The following is a description of a gene set: Human Gene Set: GSE5589_WT_VS_IL10_KO_LPS_STIM_MACROPHAGE_180MIN_DN Genes down-regulated in bone marrow-derived macrophages at 180 min of stimulation by LPS: wildtype versus IL10 knockout. studied in species Homo sapiens IL-10 or IL-6 stimulation of control 129xC57BL/6 murine bone marrow derived macrophages in the presence of LPS. We used microarrays to detail the global programme of gene expression changes in response to IL-6 or IL-10 stimulation in the presence of lipopolysaccharide. BMDMs were isolated from control, IL-6-/-, and IL-10-/- mice on a 129XBL/6 mixed background mice and differentiated in the presence of CSF-1 for 6-7 days. Cells were scraped and plated in 6 well plates at 2x10e6/well. Cells were washed with complete DMEM and rested for 1-2 hr before stimulation with combinations of IL-10 (10 ng/ml), IL-6 (2 ng/ml) or LPS (100 ng/ml) for 45 min or 180 mins. Complete biological replicates were performed. from publication El Kasmi KC, Holst J, Coffre M, Mielke L, de Pauw A, Lhocine N, Smith AM, Rutschman R, Kaushal D, Shen Y, Suda T, Donnelly RP, Myers MG Jr, Alexander W, Vignali DA, Watowich SS, Ernst M, Hilton DJ, Murray PJ (PMID 17114459), and this is the list of marker genes: GRHL1, HPCAL1, IGHG3, CTSG, OPTN, ZNRF2, SLC34A1, NR3C1 (nuclear receptor subfamily 3 group C member 1), THBD, TNFRSF13B, GLT8D2, LIG1 (DNA ligase 1), THBS2, VIM, DDAH2 (DDAH family member 2, ADMA-independent), LRRC9, NXF2, FAM124B, MAN1B1, OOSP1, CASP14, KAZALD1, DMPK, OLFM2, FBLN5 (NCBI Gene Id 11268), RASL10B, NDUFA11, GSX2, TIE1, EPHX1, FOLR2, HEPACAM2, FCRLA, DHDH, SHC4, EPAS1, OLFM1, S100A11, CBS, STMN1, ADGRG4, VAV3, NINJ1, CCDC50, PARP3, TRPV1, SERPINB12, ARHGEF28, SSBP3, ITGA4, EPX, GPC1, HGFAC, SLIT2, IL27, HOXD3, MIR676, SCARB2, EEIG2, EMILIN1, CCR10, KIRREL1, KCTD19, PSD3, SELP, NFATC4, WEE2, IFITM1, RORB, PREX1, SOCS2, AMER2, SUDS3, TPM2, JCHAIN, CLEC7A, CLEC12A (NCBI Gene Id 160364), PCDHB17P, LIX1L, EML2, ARFGEF1, CHCHD6, PHF19, FAU, CDH23 (NCBI Gene Id 7395), NRP2, TDRD7, CTRB1, BCAT2, ARL6, UBASH3B, FAM234A, GNAT2, DYNC2I1, CHGA, RNF144A, ALOXE3, FLT3, H4C16, SLC25A24, SHH, GNA13 (NCBI Gene Id 147219), ANKRD34A, RTN1 (NCBI Gene Id 8108), IRS2, SMOX, RTKN2, SOX12, TNFRSF14, GUCY1A1, SETBP1, UBQLN3 (ubiquilin 3), ZFP36L2, RNF19B, NTRK3, IGSF6, HDHD3, KCNK2, RARG, SLC1A3, PBX1, PTPRD, MYBPC2, METRNL, ASPDH, TMEM176B, ATOH7, ITM2C (integral membrane protein 2C), BLCAP, H6PD, GPRC5B, ADRA1D, DUSP16, SALL2, RNY3, H1-2, PLD4, TUBA8, PRTN3, MAPKAPK3, COPZ2, ALLC, GFI1, DSCAM, SOX13, CXADR, AGPAT2, XIAP, CST3, PAFAH1B3, DSC2, LONRF3, PRG2, PPP1R9A, RORA